Given this list of marker genes HSP90B1, NFYB, ATF6, NFYC, DDIT3, CALR, ATF4 (NCBI Gene Id 468), NFYA, HSPA5, XBP1, here is a description of the gene set: part of: ATF6 (ATF6-alpha) activates chaperones Reactome Pathway: ATF6 (ATF6-alpha) activates chaperone genes studied in species Homo sapiens The N-terminal fragment of ATF6-alpha contains a bZIP domain and binds the sequence CCACG in ER Stress Response Elements (ERSEs). ATF6-alpha binds ERSEs together with the heterotrimeric transcription factor NF-Y, which binds the sequence CCAAT in the ERSEs, and together the two factors activate transcription of ER stress-responsive genes. Evidence from overexpression and knockdowns indicates that ATF6-alpha is a potent activator but its homolog ATF6-beta is not and ATF6-beta may actually reduce expression of ER stress proteins.